Given this list of marker genes Neu2, Adam8, Ndufaf4, Mfsd11, Cfap90, Gm22322, Asf1b, G3bp1, Rab18, Rtn4, Ncf1, Btbd19, Parvb, Zfp771, Cr2, Diablo, Gm18856, Daam1, Adam3, Stau1, Gm23462, Eif4g1, Hsp90ab1, Tmcc2, Gm23212, Cdk14, Txn1, Gm6142, Numbl, Zfp963, Mir2136 (microRNA 2136), Canx, Vdac1, Ap1g1, Psmb2, Mir7232, Amotl1, Coasy, Pwwp2a, Csdc2, C030034L19Rik, Tpp2, Acadm, Zfp790, Ctdp1 (NCBI Gene Id 67655), Mat1a, Trbv1, Mrps28, 1600020E01Rik, Parp16, Gm28857 (predicted gene 28857), Cltc, Slc2a3, Gm15038, Emc9, Gm6568, Hycc1, Smyd4, Crlf3, Gm21362, Gm12092, Nup153, Atf1, Frmd8os, Srp19, Rpl15, Gm27042, Myl6b, Cxcl10, Gca, P2ry12, Brd2, Rc3h1, Ino80, Mir22hg, Papss2, Rnpep, Gnat2, Akap8l, Eif1ax (eukaryotic translation initiation factor 1A, X-linked), Adgre5, Cbr3, Ogfod2, Dysf, B230104I21Rik, Kbtbd12, Pir, Snord78, Atp8b4, Unc80, Fh1, Myo18a, Gsk3b, Gm13073, Or1e1, Slc39a13, 1700010B13Rik, Tmem38a, Trak2, Slc1a2, Gm18861, Spta1, Mast2, Ubr4, Taldo1, Gm15267, Commd1, Cst7, Ppm1f, Gm7299, 9430087B13Rik, Mir22, 4933435F18Rik, Gm22488, Dpf2, Hnrnpa2b1, Gm25134, Mmp9, Pold2, Rtca, Rab6a, Zfp652, Serpinb9b, Gm13590, Dock9, H3c6, Pgs1, Nars1, Smim7, Slco1c1 (solute carrier organic anion transporter family, member 1c1), Rmrp, Srxn1, Csf1, Gm20658 (predicted gene 20658), Tomm20, Mogat1, Arhgap21, Crtc1, Afdn, Gm25549, Sapcd2, Plaa, Gm32585 (NCBI Gene Id 102635182), Isy1, Mir5627, Trafd1, Mylk, Nt5dc3, Rsad2, Nkiras1, A530013C23Rik, Gm11420, Atl3, Dnmt3l, Psmd1, Cd1d1, Slc36a1os, Gm15567 (NCBI Gene Id 100503685), Cdc42se1, Gm15201, Mir3075, E030042O20Rik, Slc11a1, Rapsn (receptor-associated protein of the synapse), Sqstm1 (NCBI Gene Id 18412), Gm12542, Cxcl5 (C-X-C motif chemokine ligand 5), Mapkap1, 2700049A03Rik, Slc38a10, Smim3, Tuba4a, Txlnb, Slc22a4, Zfp426, Lpin3, Gm9951, Cpsf6, Zwint, Metap2, Pafah1b1, Tedc2, Fyb1, Slc7a11, Gm26224, D630024D03Rik, Serpinb9, Gm26854, Creg1, Ubxn7, D030040B21Rik (RIKEN cDNA D030040B21 gene), Myo1e, Zfp414, Slc25a38, 2900093K20Rik, Aox1, Nsmce1, Itfg1, Gm20655, Mri1, Kbtbd7, Ss18l1 (SS18, nBAF chromatin remodeling complex subunit like 1), Bdh2, Prdx2 (NCBI Gene Id 98489), Gstm1 (glutathione S-transferase, mu 1), P2rx6, Calcoco1, Zcwpw1, Zer1, Dynlt4, Lrrc74b, Pcyox1l, Slc24a5, Tbcel (tubulin folding cofactor E-like), D030047H15Rik, Zmynd8 (NCBI Gene Id 99150), Angpt1, Dmc1, Sass6, Mocs1, Gm12758, Rida, Clcf1, 4930486L24Rik, Gpr137, A630095N17Rik, Arhgap15, Bicdl1, AU015336, Ptch1, Maml3, Igkv12-38, Gm10222, 5033404E19Rik, Gm12976 (predicted gene 12976), Arap1, Lrrc8d, Oser1, Gm24708, Keap1, 1700013A02Rik, Nprl3, Atosa, H2-T22, Vezt, Ubb, Faf1, Gm14164, Cdc42bpa, Mrpl14, Map2k7, Ptges3, Tfec, H2bc27, Pcbp3 (NCBI Gene Id 59093), Gm8242 (predicted gene 8242), Lrrk1, Gm22357, Dnai1, Rmc1, Inpp5b, Ston2, 2210408F21Rik, Pxmp4, Npm2, Gp5, Hbb-bs, Tnpo1, Scml4, Loxl3, Mllt3, Eloc, Mfsd14a, Csgalnact2, Lgalsl, Ankle1, Ahsa1, Tpm3, Mef2c, Cox20, Birc6, 1700017G19Rik, Leng8, Mepce, Arhgap23, Sugp2, Lrrfip2, Prss55, H6pd, Sds, Gcc1, Ubc, Stam2, Rpl22l1 (ribosomal protein L22 like 1), Mir1668, Pkd1, Ccdc107, Efhd2, Gbe1 (1,4-alpha-glucan branching enzyme 1), Gm32950, Dnajc13, Sec31a, Zfand5, Tpbpa, Slc45a4, Mrpl32, Slc22a12, A730036I17Rik, Olfm2, Rassf3, Arl8a, Plcg1, Clip1, Ikbkg, Vipas39, Evi2b, Cimap2, Msh3, Psmb6, Twf2, Srd5a3, Gm18827, Acss2, Adgrg1, Gm6034, Egln2, Spmip2, Srrm2, Igfn1, Rpl11, Liph (NCBI Gene Id 28111), Psma7, Gm2447, 1700025N21Rik, Fgd4, Izumo1, Pf4, Thra, Rbm25, Cd46, Smg5, Btnl9, Cbx3, Bad, Ncf2, Usp14, Rusc2, Ifrd1, Ctla2b, Abcb6, Gclm, Klc1, Mgst2, Prdm16, Furin, Gapdh, Park7, Gas5, Kat2b, Tmem209, Gm10557, Adrm1, Fancc, Asl, Gm22489, Agrn, Atf6b, Stoml1, Capn2, Lztfl1, Calr3, Tmt1a, Zbtb37, Arrb2, Mafg, Gsr (NCBI Gene Id 52270), Psmd11, Gm6565, Timm13, Rex1bd, Osbp, Crcp, Glrx, Oxsm, Robo3, Cep112, Med13, Psme3, Gm26328, Pitpnm3, Katnal1, Ndel1, Wdfy3, Cavin2, Rbks, Tbxas1, Ehd1, Zswim1, Popdc2 (NCBI Gene Id 64082), Vmn1r33, Mllt11, Arhgdib, BC005537, Dnajb9, Gm23100, B230317F23Rik, Atg7, Ctla2a, Rheb, Dnajb1, Prdx1, Slc4a1, Rps14, Il6, Creld1 (NCBI Gene Id 171508), Ccser1, Sufu, Atf7ip, Dstn, Midn, Gm12925, F2r, Stk40, Bptf, Zfp91, Vcp, Gm23463, Pecam1 (NCBI Gene Id 97748, platelet/endothelial cell adhesion molecule 1), Slc20a1, Ppa2, Srsf2, Fam32a, Tgfbr3, Cdca2, Gtf2a2, Ints2, Zbtb20, Cenpu, 4931440P22Rik, Scarletltr, Kdm2a, Pla2g6, Rn7s6, Hmgb1-rs16, Dapk2, Nbeal2, Treml2, Tmem161a, Fam219a (NCBI Gene Id 71901), Gm15565, Mir6236, Knstrn, Agfg1, Aldh9a1, Aldoa, Zcchc17, Gm11663, 1700101I11Rik, Plscr3, Ppcdc, Niban2, Nuggc, Snx10, Ctsd, Slc39a4, Serpina5, Gtf2a1, Hapstr1, Pitpnm2, Nol11, Pkd1l2, Snrpc, St7, Peds1, Zfp367, Fgfr2, Ccl24, Rnf113a2, Aldh18a1, Abcf3 (ATP-binding cassette, sub-family F member 3), Ttll11, Gm12739, Pla2g12a, Fetub, Rbbp7, 4930519L02Rik, Ptafr (platelet-activating factor receptor), Mocos, Hacd4, Tdrd7, Scmh1, Sftpa1, Fam107b, Tmbim6, Iftap, Clcn3, 3300005D01Rik, 4930412C18Rik, Shc1, Txnl1, Flot1, Gm12762, Fmn1, Bsdc1, Rpl14, Ncor1, Gm12513, Evi5, Maco1, Cyp4f37, Mir6347, Usp10, Tlcd2 (TLC domain containing 2), Txnrd1, Psmc1, Adnp2, Cilp (cartilage intermediate layer protein, nucleotide pyrophosphohydrolase, NCBI Gene Id 214425), Zfp574, Atp6v0a1, Nqo1, Dagla, here is a description of the gene set: Mouse Gene Set: NFE2_TARGET_GENES Genes containing one or more binding sites for (Nfe2) in their promoter regions (TSS -1000,+100 bp) as identified by GTRD version 20.06 ChIP-seq harmonization. from publication Yevshin I, Sharipov R, Kolmykov S, Kondrakhin Y, Kolpakov F (PMID 30445619) species: Mus musculus